Given this list of marker genes MTMR4 (myotubularin related protein 4), TMEM138, DCUN1D3, BAHD1, KLHL18, DHRS11, SMG5, SURF2, NSUN5P1, TRAPPC14, GGT7, MBD3, SUV39H1, RMND5B, DENND4A, METTL17, S100PBP, VRK3, BOD1L1, TRAFD1, GFM2, TMEM120A, POLR2M, EIF4EBP2, BABAM1, ABHD16A, C1orf52, DDX47 (NCBI Gene Id 51202), TADA2B, CHUK, MMAB, PSME3, FBXL20, URGCP, TINF2, RABIF, PYM1, SAFB, SIN3A, PRDM4 (PR/SET domain 4), AP2A1, COQ10A (NCBI Gene Id 93058), CS, ANAPC5 (NCBI Gene Id 51433), SUMF2, THAP4, DPH7, MRPS5, DHX37, TAOK2, CFAP298, TUT1, COMMD9, DBNL, TMX3, RRP9, SNX33 (sorting nexin 33), PRKD2, TBC1D10B, TEX261, ING1, PEX11B, SCAMP2 (NCBI Gene Id 10066), CNOT11, CNPPD1, VPS53, NF2, here is a description of the gene set: studied in species Homo sapiens Human Gene Set: GCM_ING1 Neighborhood of ING1 inhibitor of growth family, member 1 in the GCM expression compendium Neighborhood of ING1